The following is a description of a gene set: species: Homo sapiens Human Gene Set: HP_PROXIMAL_MUSCLE_WEAKNESS Proximal muscle weakness A lack of strength of the proximal muscles., and this is the list of marker genes: SMPX, GNE, RILPL1, CAV3, MORC2, ATP6V1E1, MEGF10, DGUOK, FHL1, VWA1, SDHB, HK1, ALG2, RRM2B, SGCA, MUSK (NCBI Gene Id 4593), LRIF1, RYR1, LAMB2, LRP4, ITPR1, EGR2, LPIN1, DAG1, SBF2, ALS2, TNXB, HACD1, SCN4A, GIPC1, CASQ1, KY, TK2, NAA80, TARDBP, SNUPN, LAMA2, OBSCN, CAVIN1, SQSTM1, ADSS1, CHRNE, COL12A1, GFPT1, JAG1, MSTO1, DNA2, SLC12A6, LDB3, DYSF, ABHD5, POLG2 (NCBI Gene Id 11232), TBK1, JAG2, ACTN2, BVES, MICU1, OPA1, DNAJB6, CPOX, MPV17, NDRG1, LARGE1, DYNC1H1, FXR1, OAT, COQ8A, SDHAF1, MYBPC1, HNRNPA1, CHRNA1, POLR3GL, NUTM2B-AS1, NARS2, DMD, BICD2, MLIP, POPDC3, HMGCR, BIN1, MYO9A, CHRND, HLA-DRB1, CFL2, MTAP, FUS, SORD, TMEM43, AK9, PPOX, MT-TL2, FILIP1, PRX, MTMR14, COL6A3, MYL1, TRIM32, POMT2, ANXA11, MT-TE, HEXB, CHCHD10, RNU12, MAP3K20, POMK, KCNJ18, PNPLA2, UBA1, FLNC, VMA21, MFN2, FKTN, NEFH, SLC25A1, FKRP, SMN1, UNC45B, RUSC2, PHKG1, RBCK1, COLQ (collagen like tail subunit of asymmetric acetylcholinesterase, NCBI Gene Id 8292), MYH2, SLC25A4, PLEKHG5, HMBS (hydroxymethylbilane synthase), MYMK, LMNA, TPM3 (NCBI Gene Id 91191), MB, MYF6, LTBP4, SLC5A7, SH3TC2, POMGNT1, IGHMBP2, ATXN1, RYR3, SLC25A21, FDX2, TFG, ACTA1, POMGNT2, GAN, GDAP1, MT-CO3, ATP7B, DPM3, SDHD, MT-TL1, SYT2 (synaptotagmin 2), PYROXD1, COL9A3, MTMR2, SLC22A5, GAA (alpha glucosidase), TPM2, SGCD, GABRA3, SPG11, CRPPA, DMXL2 (Dmx like 2), STAC3 (NCBI Gene Id 246329), PMP22, VCP, COQ7, SNAP25, DES, TOP3A (NCBI Gene Id 7156), MYPN, PABPN1, CRYAB, CAPN3, CHKB, REEP1, NEFL, SECISBP2 (SECIS binding protein 2), PYGM (glycogen phosphorylase, muscle associated), PHKA1, ANO5, TRAPPC11, MPZ, FLAD1, RAPSN, PUS1, GOSR2, HSPG2, SPEG (striated muscle enriched protein kinase), NEB, ARMC5, ITGA7, TCAP, VAPB, ASCC3, NOTCH2NLC, CPT1C, TMEM126B, SDHA, AGRN, CNBP, BTNL2, MYOT, NDUFA1, POMT1, INPP5K, STIM1, TWNK, SPTLC1, PNPLA8, DNM2, MT-ATP6, POLRMT, SIGMAR1, GMPPB, VAMP1, BAG3, COL6A1, SMN2, SLC25A42, ACBD5, COL13A1, JPH1, MYH14, COL6A2, KCNE3, FBXO38, ORAI1, TAMM41, ACADM, POGLUT1, ASAH1, SGCG, CAPRIN1, PRKACA, MT-CO1, TNNT1, SPTAN1, CACNA1S, SYNE1, TAFAZZIN, GNAS, SLC18A3, GATM, DPAGT1, EMD, VRK1, SYNE2 (spectrin repeat containing nuclear envelope protein 2), CHRNB1, SELENON, LRP12, LAMP2, DOK7, ALG14, SLC9A7, KDM1A, PLEC, LIPE, SGCB, SLC52A3, SRPK3, MT-TN, POLG, TTN, TRPV4, RTN2, CHAT (choline O-acetyltransferase), TRDN, PREPL, MYH7, PIGN, HNRNPA2B1